The following is a description of a gene set: electronically inferred by orthology from the curated human pathway species: Mus musculus part of: Regulation of PD-L1(CD274) Post-translational modification Reactome Pathway: PD-L1(CD274) glycosylation and translocation to plasma membrane This event has been computationally inferred from an event that has been demonstrated in another species.<p>The inference is based on the homology mapping from PANTHER. Briefly, reactions for which all involved PhysicalEntities (in input, output and catalyst) have a mapped orthologue/paralogue (for complexes at least 75% of components must have a mapping) are inferred to the other species., and this is the list of marker genes: Stt3a, Tusc3, Stt3b, Pdcd1lg2, Pdcd1, Ddost, B3gnt3, Mib2, Ubb, Cd274, Dad1, Ost4, Tmem258, Rps27a